The following is a description of a gene set: Mouse Gene Set: chr3G2 species: Mus musculus, and this is the list of marker genes: 4933424H11Rik, Mir367, Larp7, Mir302c, Gm22293, Ank2, Gm10650, Fam241a, Alpk1, 1500005C15Rik, Gm16958, Gm25501, Gm16238, A930036I15Rik, 9830132P13Rik, D030025E07Rik, Mir302b, Zgrf1, Mir302d, Tifa, Ap1ar, Gm35585, Gm35667, Neurog2, Mir302a